The following is a description of a gene set: studied in species Mus musculus A process in which a protein is transported to, or maintained in, a location within a cell junction. Mouse Gene Set: GOBP_PROTEIN_LOCALIZATION_TO_CELL_JUNCTION, and this is the list of marker genes: Dlg1, Nbea, Tmem108, Lamtor2, Mpp4, Asic2, Dlg4, Fermt2, Nptx1, Homer1, Cacng7, Nptx2, Zdhhc2, Traf6, Magi2, Nectin1, Flna, Dsp, Ghsr, Baiap2, Cdh5, Adam10, Mapk8ip3, Afdn, Stx1b, Tjp1, Gphn, Cacna2d2, Iqsec2, Gpsm2, Cgnl1, Erbb2, Stau1, Abcb1a, Gripap1 (GRIP1 associated protein 1), Adam22, Kif5a, Mapk8, Snap23, Tnik, Camk2a, Vps35, Lrrc7, Bsn, Rap1a, Abhd17b, Grin2c, Neto2, Dsg3, Gabarap, Kif2c, Nectin3, Dlg3, Actg1, Dsg2, Vcl, Cplx1, Tjp2, Clstn1, Grip2, Hepacam, Zdhhc12, Ogt, Dlgap1, Grip1, Actn4, Vwc2, Arhgap44, Actb, Gpc6, Hspb1, Heg1, Nlgn1, Zdhhc7, Rab11a, Jak1, Cacng3, Sacm1l, Grin1, Nphs1, Ildr1, Kif5b, Map1a, Kif5c, Mapt, Lrrtm1, Prkcz, C1ql2, Kalrn, Rapgef4, Dok7, Scrib (scribbled planar cell polarity), Shank1, Nsg1, Stx4a, Erbb4, Mapk9, Cnih3 (NCBI Gene Id 72978), Cdk5, Agrn, Rapsn, Musk, Nlgn3, Mapk10, Snap47, Nptxr, Marveld3, Pak2, Stau2, Stx3, Dag1, Zdhhc15, Dlg5 (discs large MAGUK scaffold protein 5), Lhfpl4, Pclo, Reln (reelin), Vps26b, Rab27b, Jam3, Gsk3b, Nrxn2, F11r, Mylk, Map2k1, Nrxn1, Ctnnd1, Rab8a, Dlg2, Gpc4, Klc1, Clstn3, Olfm2, Vamp2 (NCBI Gene Id 22318), Neto1, Grin2a, Slitrk3, Lgi1 (NCBI Gene Id 56839), Lsr, Lamtor3, C1ql3, Epb41l1, Hras, Git1, Arhgef18, Tjp3, Nrxn3, Nlgn2, Kif3a, Pecam1, Cacng2, Mpp7